The following is a description of a gene set: The process comprising the insertion of proteins from outside the organelle into the mitochondrial outer membrane, mediated by large outer membrane translocase complexes. Human Gene Set: GOBP_PROTEIN_INSERTION_INTO_MITOCHONDRIAL_OUTER_MEMBRANE studied in species Homo sapiens, and this is the list of marker genes: MTCH2, TOMM6, TOMM40, TOMM70, MTX1, MTX2, MTCH1, TOMM20, TOMM5, SAMM50, TOMM22, TOMM7